Given this list of marker genes MAPK3 (mitogen-activated protein kinase 3), MAP2K1, BRAF, SRC, PGR, MAPK1, HRAS, GRB2, SOS1, RAF1, CCND1, ARAF (NCBI Gene Id 369), MAP2K2, KRAS, NRAS, SOS2, here is a description of the gene set: P4-PR-RAS-ERK signaling pathway. Pathway ID: N01360. Pathway type: Reference. Pathway class: nt06210 ERK signaling. studied in species Homo sapiens Human Gene Set: KEGG_MEDICUS_REFERENCE_P4_PR_RAS_ERK_SIGNALING_PATHWAY Pathway Definition from KEGG: P4 -> (PGR+SRC) -> GRB2 -> SOS -> RAS -> RAF -> MEK -> ERK -> CCND1